Given this list of marker genes NTHL1, ALKBH1, OGG1, NEIL3, NEIL1, RPS3, NEIL2, POLB, here is a description of the gene set: Catalysis of the cleavage of an AP site 3' of the baseless site by a beta-lyase mechanism, leaving an unsaturated aldehyde, termed a 3'-(4-hydroxy-5-phospho-2-pentenal) residue, and a 5'-phosphate. studied in species Homo sapiens Human Gene Set: GOMF_CLASS_I_DNA_APURINIC_OR_APYRIMIDINIC_SITE_ENDONUCLEASE_ACTIVITY